Given this list of marker genes KCTD6, ESR1, CBFB, GPAM, RUNX1, AXIN1, here is a description of the gene set: part of: Transcriptional regulation by RUNX1 The RUNX1:CBFB complex can associate with the activated estrogen receptor alpha (ESR1) through direct interaction between RUNX1 and ESR1. The RUNX1:CBFB complex is thus involved in transcriptional regulation of estrogen responsive genes, including GPAM, KCTD6 and AXIN1. High GPAM expression correlates with better overall survival in breast cancer. species: Homo sapiens Reactome Pathway: RUNX1 regulates estrogen receptor mediated transcription